The following is a description of a gene set: Genes down-regulated in NKT cells versus B1 B lymphocytes. Three innate (B1-B, NKT, CD8aaT cells) and adaptive (B2-B, CD4T, CD8abT cells) cell-types were sorted by FACS. Three biological replicates for NKT, CD4T, CD8aaT, CD8abT cells and two biological replicates for B1 and B2 cells were generated and the expression profiles were determined using Affymetrix Mu74Av2 chip. Comparisons between the sample groups allow the identification of genes differentially expressed between the innate and adaptive cell-types. from publication Yamagata T, Benoist C, Mathis D (PMID 16623764) Human Gene Set: GSE3039_NKT_CELL_VS_B1_BCELL_DN species: Homo sapiens, and this is the list of marker genes: SUB1, EPRS1, STK38L, MCM6, NRP1, MAGED1, RPS3, CCT2, TMEM273, GAS7, PAPSS1, RABGGTB, ATOSA, PTCH1, HNRNPA0, OPA1, TMEM147, MTOR, CHRAC1, FBLN2, GNA12, RRM1 (ribonucleotide reductase catalytic subunit M1), COQ6, PRDX3, LMNA, ARL4A, H1-0, CSE1L, MRPS22, CHD3, ARMC1, DMAC1, HYCC1, PHKA1, GID4 (GID complex subunit 4 homolog), PTRHD1, TUFM, DNAJA3, MSMO1, TMEM107, ATP7A, PBX3, TRIP6, FGFBP1, WDR75, PLPP3, ANKRD28, TMEFF1, AURKA, P2RX4, RPL19, FAM135A, ESR1, TUBB, FASTKD2, VAMP7, CDT1, NUCKS1, HPGDS, RNF180, PLBD1 (NCBI Gene Id 79887), ZNF330 (NCBI Gene Id 94900), HDDC2, SULF2, AGO2, TIMP2, PSMB4, MYO1B, TRIB2, SNX2, MLLT11, RPAP2, CDK14, DNMT3A, KDM2B, C1orf198, COX4I1, TTC9, BLOC1S5, VCL, ASPM, PDPR (pyruvate dehydrogenase phosphatase regulatory subunit), RPL34, H2BC13, TNS4, TUBB6 (tubulin beta 6 class V), SNX8, NDUFAF5, YARS1, AKAP11, DBP, EDNRB, UTP25, GPR34, INTS10, QSER1, RNASEH2B, GINS1, TACC3, ARHGAP18 (NCBI Gene Id 93663), SERPINB2, SMG6, APTX, DSC2, FKBP2, CYSLTR1, CUL7, GTF3C4, SLC4A7, TBC1D31, PTRH1, TSC22D2, CUL2, NCAPH, ARHGEF10, POMGNT1, GPX7, FYTTD1, P2RY6, FXN, ALAD, NHSL3, HK2, COX16, ADAT2, FAM219A, IPO5, PARP1, BAIAP2, CHD1L, TSC22D1, ATIC, PURA, KNSTRN, RPS18, MIB1, LRRC40, USP36, SH3RF1, H2AX, SPC25 (NCBI Gene Id 57405), FAM117A, TPCN1, POLA1 (NCBI Gene Id 5422), BLNK, TRAF3, APOLD1, TMLHE, CSTF2, TTK, SMUG1, ARL2 (NCBI Gene Id 402), PHTF2, RAI1, TAMM41, GSTM3, CTH, BUB1, FBN1, ITM2C, WDR43, LAS1L, MND1, NPRL2, CEP152, MYO5A, ATP5MC3, GPR183, TMEM54, WDR74, USP24, FAM162A, MRPL46, SMARCAL1, TSEN2, GDPD1, CEP41, DOK1 (docking protein 1), NCBP2AS2, UBXN8, SLC7A6, LRRC42, TK1, ANKRD50, NAGLU, ACO1 (aconitase 1), TMEM9, PRODH, ATP8B2, TMCC3, CXCL16, MRPS10, DPH6, CCDC32, TPI1, MS4A6A, LYVE1, ARL4C, CD99L2, VKORC1